The following is a description of a gene set: species: Homo sapiens from publication Amit I, Garber M, Chevrier N, Leite AP, Donner Y, Eisenhaure T, Guttman M, Grenier JK, Li W, Zuk O, Schubert LA, Birditt B, Shay T, Goren A, Zhang X, Smith Z, Deering R, McDonald RC, Cabili M, Bernstein BE, Rinn JL, Meissner A, Root DE, Hacohen N, Regev A (PMID 19729616) mouse primary BMDCs were stimulated with tlr ligands and gene expression changes were profiled on Affymetrix arrays Genes up-regulated in comparison of dendritic cells (DC) stimulated with poly(I:C) (TLR3 agonist) at 8 h versus DC cells stimulated with Pam3Csk4 (TLR1/2 agonist) at 8 h. Human Gene Set: GSE17721_POLYIC_VS_PAM3CSK4_8H_BMDC_UP, and this is the list of marker genes: TAMM41, NRDE2, TMEM45B, TRIP10, SLC43A3, CSRP1, RARS1, ATG3, CCR1, MARK3, IDNK, ICAM2, LCK, PNRC1, SGK3, ELOA, APAF1, PBX1, PRR14, PXMP2, BCKDHB, GINS4, RBMS1, TOB1, ECHDC2, OGA, FOXK1, ANKIB1 (NCBI Gene Id 54467), GTPBP2, WNK1, PLEKHA2, FAM3B, TIGD5, AOX1, NR1D2, EVI2B, LAPTM4A, AAMDC, BRCA1, STARD3NL, NBL1, KDM3B, PMPCB, SP4, UBC, PPP2R2A, CCL13 (NCBI Gene Id 6357), CBX4, MOB1A, NDRG1, DDX4, NAAA, TTC36, RAB25, SMAGP, COPZ1, PKD2L2, RRBP1, RSRP1, CNTLN, SERPINB1, RHOV, ABHD10, VIRMA, METRNL, NPTXR, GLIPR2, HIPK2, RBBP8, FABP4, AKAP12, SPDL1, TCAF2, STX2, ECE2, ZBTB7B, AVL9 (AVL9 cell migration associated), ARHGAP12, VCAN, AKIRIN2, RAB5IF, CTDSP2, PPDPF, CIITA, VIM (vimentin), UPK3B, AP3M2, TRIP12, NOTUM, MBD6, FBXO4, GTF2F1, S100PBP, COX20, FAM53C, STK24, ST6GALNAC4, C6orf62 (chromosome 6 open reading frame 62), CERT1, ING2, FBXW7, FRG1, NR3C1, CHD1, ANPEP, MBD4, HK1, TAOK3, CDKN1B, SPP1, GLA, STAG2, DLGAP4, SMC5, MSANTD2, COX6A2, TRDMT1, COMMD5, TBXAS1, SPTLC2, ZFAND6, FLII, SMPD3, TFG, PDLIM1, KLF10 (KLF transcription factor 10), S100A8, SMAD4, HOOK2, BZW2, SH3BP5L, MAL2, CABP4, FKBP10, PLSCR1, SNX4, KRCC1, FAM83F, TRIM21, MBTD1, WFS1, MRAP, TTC39B, PRKX, LGALS3BP, IRF9, NSMCE4A, WAC, SELENOT, MAFB, LSR, MBNL1, MAN2A1, SEMA4F, NMBR, CCR7, NCOA4, KLHL22, UBR4, KLF3 (NCBI Gene Id 51274), PKIB, TNNI3, ANAPC5, MSRB2, RLF, PROS1 (NCBI Gene Id 5627), ACYP2, RGS10, ETHE1, ASGR2, TSPAN31, IL10RA, PTPN18, MACROH2A1, TRIP6, BATF2, PSME3IP1, MID2, PER1, STAT4, SERINC3, RASA2, ZNHIT1, PTRHD1, POLB, NR1H2, CLYBL, FYN (NCBI Gene Id 2534), MYLK2, NAA20, MRPL4, PTCH1, REST, CUTC, STK4, NTS, CHST15, NFKBIE, ITSN2, ARFGEF1 (NCBI Gene Id 25860)